Given this list of marker genes ADCY9, CHGA, ATP2B4, GPR88 (NCBI Gene Id 54112), PDE4D, ADRA2B, RAPGEF2, AKAP13, ARRDC3, ADRA1A, ADRB1, PLN, GNAS, MIR30E, RGS2, ZDHHC21, ADRA1D, LMBRD2, ADRB2, MIR133A1, ADRA2C, ADRA2A, KCNQ1, DRD5, CRTC3, MIR1-1, DRD1, GNAI2, ADRA1B, PDE4B, GSK3A, GPR101, ADRB3, here is a description of the gene set: species: Homo sapiens A G protein-coupled receptor signaling pathway initiated by a ligand binding to an adrenergic receptor on the surface of a target cell, and ending with the regulation of a downstream cellular process. Human Gene Set: GOBP_ADRENERGIC_RECEPTOR_SIGNALING_PATHWAY